Given this list of marker genes Vcp, Prkci, Psmd14 (proteasome (prosome, macropain) 26S subunit, non-ATPase, 14), Gpx7, Cox4i2 (cytochrome c oxidase subunit 4I2), Gstp2, Psma6, Psma3, Ppara, Txnrd2, Psmd3, Cox6a1, Ncoa2, Psmd6, Nploc4, Cox6b1, Psmb2, Map1lc3b, Prdx6, Cat, Cox7a2, Sod3, Helz2, Cox8a, Psmb3, Adrm1, Mul1, Psmb6, Cox6b2, Psmd12, Sesn1, Tbl1x, Ncoa1 (NCBI Gene Id 17977), H13, Uba52, Akt1, Psmd2, Fabp1, Sin3a, Skp1, Psmb4, Sod2, Gpx2, mt-Co3, P4hb, Sin3b, Tgs1, Gpx6, mt-Co2, Cox6c, Ncf2, Gpx3, Tbl1xr1, Med1, Cox7a2l, Gsk3b, Uba52rt, Sqstm1, Hba-a1 (hemoglobin alpha, adult chain 1), Hdac3, Psma7, Sesn2, Cox7a1, Ndufa4, Ubxn7 (NCBI Gene Id 381042), Psmc5, Psmc3, Cul3, Nox4, Prdx1, Txn1, Chd9, Blvrb, Psmd7, Cybb, Psmd8, Srxn1, mt-Co1, Txn2, Psma4, Carm1, Ncf4, Psmb5, Ubc, Psmc6, Prdx3, Gpx8, Bach1, Akt3, Gsr, Txnrd1, Sod1, Akt2, Psmd11, Cox8c, Prdx2, Mafk, Prkaa2, Cox4i1, Cycs, Gpx1, Hbb-bt, Cox7c, Psmd13, Skp2, Nfe2l2, Psma5, Rxra, Ccs, Ep300, Fbxl17, Higd1c, Psmc2, Abcc1, Ncf1, Ncor2, Ufd1, Cox5a, Gstp1, Psmc1, Ubb, Trim21, Cox7b, Prdx5, Gm10053, Rps27a, Cox6a2, Psmc4, Ero1a, Nudt2, Psma2, Hmox1, Cox5b (NCBI Gene Id 12859), Rbx1, Psmb7, Psma1, Psmd1, Cyba, Psmb1, Smarcd3, Blvra, Cul1, Keap1, Hmox2, Gpx5, Hbb-bs, Alb, here is a description of the gene set: species: Mus musculus Cellular response to chemical stress Mouse Gene Set: REACTOME_CELLULAR_RESPONSE_TO_CHEMICAL_STRESS